The following is a description of a gene set: studied in species Homo sapiens Human Gene Set: GOBP_DNA_REPLICATION_CHECKPOINT_SIGNALING A signal transduction process that contributes to a DNA replication checkpoint, that prevents the initiation of nuclear division until DNA replication is complete, thereby ensuring that progeny inherit a full complement of the genome., and this is the list of marker genes: TOPBP1, CLSPN, CDC45, HUS1, ZNF830, ORC1, TIMELESS (NCBI Gene Id 8914), DNA2, HUS1B, RAD17, CDC6, RAD9B, MDC1, NAE1, RAD9A, CDT1, DONSON, TICRR, CAMSAP3, TIPIN